Given this list of marker genes TACR3, PROKR2, PRDM12, SEMA3A, SNCA, DNAJC13, ATP7B, VPS13C, SPRY4, ATP13A2, NDNF, ADCY3, SCP2, PINK1, CCDC141, GIGYF2 (GRB10 interacting GYF protein 2), FEZF1, DNAJC6, NSMF, HESX1, GBA1, DCC, EIF4G1 (eukaryotic translation initiation factor 4 gamma 1), SCN9A, SYNJ1, PTPN11, PRKN, VPS35, FGF17, CEP290, PODXL, HS6ST1, FLRT3, DUSP6, LRRK2, UCHL1, SOX10, DDX6, TSHZ1, LZTFL1, IL17RD, IFT27, SMCHD1, PARK7, SLC39A14, WDR11, FGF8, HTRA2, FGFR1, CHD7, ANOS1, PROK2, here is a description of the gene set: A decreased sensitivity to odorants (that is, a decreased ability to perceive odors). Human Gene Set: HP_HYPOSMIA studied in species Homo sapiens Hyposmia